Given this list of marker genes PARP3, CYLD, THY1, DGKA, ANKRD44 (NCBI Gene Id 91526), CYSLTR2, IL15RA, IFIT2, STXBP1 (NCBI Gene Id 6812), PRKCH, TRIM14, DPYD, HIVEP1, MCL1, TCF25, TRIM25, VWA5A, NOD1, CD69, DOK2, XAF1, CXCL9, GSAP (NCBI Gene Id 54103), EIF4E3, P2RY10, TLR2, PLA2G4C, AIM2, ERAP1, KLRC1, NCKAP1L, ESYT1, FURIN, PNPLA7, ESR1, CSF1, PLCB2, MCTP2, SLAMF7, GIMAP6, FYN, CD3E, LMO4, CCRL2, RNF19B, MERTK, UVRAG, ITGAL, IL18R1, CXCL10, STAT3, PPP6R1, TGIF1, GIMAP4, KLRK1, CASP4, TGM2, PIK3CG, ATP2B4, PRDM1, USP4, GRAP2, PTPN22, PLA2G4A, LCK, NOTCH1, CD8A, SH3BP2, SCN1B (NCBI Gene Id 6324), CALHM6, IL18BP, PARP12, TEX14, IRF1, MX1, HPSE, IL2RA, KLRG1, KCNJ13, IFIT3, CYRIA, CXCR6, STX11, BRD7, GGT1, PHF11, RNF115, ICOS, EPSTI1, CIITA, CD96, ATP8A1, VCAM1, PSMB8, CASP1, PLSCR2, TNFRSF14, CHSY1, TNFSF10, USB1, UNC93B1, CD3D, BID, SLC2A6, ABCA1, GZMA, FBXL5, UBD, SOCS1, TAPBP, RSPO3, PSMB9, PDCD1, PARP11, IL27RA, MYO1G, AHNAK, RBM43, KLHL6, GBP6, NR5A1, CD300C, GNB4, BATF2, IDO1, SDC3, KAT2B, CLEC2D (NCBI Gene Id 29121), PSMB10, PTPN6, SEMA7A, SAMD9L, ASB13, IRAK2, UPP1, PDGFD, CST7 (cystatin F), USP18, SERPING1, ACER3, CTSO, ICAM1, SP110, ELL2, MXD1, PIK3CB, LPIN2, ISG15, TRIM5, IL12RB2, NFKBIA, AZIN2, ADGRG5, TMTC4, OAS3, C6orf62 (chromosome 6 open reading frame 62), SLC7A3, GZMK, CORO2A, MLKL, NLRC5, INSRR, ABHD16A, CBLB, IFI44, ATP8B4, LY75, SLC28A2, SEMA4D, CORO1A, ENC1, TNFRSF9, here is a description of the gene set: Genes down-regulated in immature dendritic cells: untreated versus interferon alpha. Human Gene Set: GSE7509_UNSTIM_VS_IFNA_STIM_IMMATURE_DC_DN The ability of dendritic cells (DCs) to activate immunity is linked to their maturation status. In prior studies we have shown that selective antibody-mediated blockade of inhibitory FcgRIIB receptor on human DCs in the presence of activating immunoglobulin (Ig) ligands leads to DC maturation and enhanced immunity to antibody-coated tumor cells. Here we show that Fcg receptor (FcgR) mediated activation of human monocytes and monocyte-derived DCs is associated with a distinct gene expression pattern, including several inflammation associated chemokines as well as type 1 interferon (IFN) response genes including the activation of signal transducer and activator of transcription 1 (STAT1). from publication Dhodapkar KM, Banerjee D, Connolly J, Kukreja A, Matayeva E, Veri MC, Ravetch JV, Steinman RM, Dhodapkar MV (PMID 17502666) studied in species Homo sapiens